The following is a description of a gene set: studied in species Homo sapiens After being synthesized in the ER membrane the 14-sugars lipid-linked oligosaccharide is co-translationally transferred to an unfolded protein, as described in the previous steps. After this point the N-glycan is progressively trimmed of the three glucoses and some of the mannoses before the protein is transported to the cis-Golgi. The role of these trimming reactions is that the N-glycan attached to an unfolded glycoprotein in the ER assume the role of 'tags' that direct the interactions of the glycoprotein with different elements that mediate its folding. The removal of the two outer glucoses leads to an N-glycan with only one glucose, which is a signal for the binding of either one of two chaperone proteins, calnexin (CNX) and calreticulin (CRT). These chaperones provide an environment where the protein can fold more easily. The interaction with these proteins is not transient and is terminated by the trimming of the last remaining glucose, after which the glycoprotein is released from CNX or CRT and directed to the ER Quality Control compartment (ERQC) if it still has folding defects, or transported to the Golgi if the folding is correct. The involvement of N-glycans in the folding quality control of proteins in the ER explains why this form of glycosylation is so important, and why defects in the enzymes involved in these reactions are frequently associated with congenital diseases. However, there are many unknown points in this process, as it is known that even proteins without N-glycosylation sites can be folded properly (Caramelo JJ and Parodi AJ, 2008). Reactome Pathway: N-glycan trimming in the ER and Calnexin/Calreticulin cycle part of: Asparagine N-linked glycosylation, and this is the list of marker genes: OS9, PDIA3, ENGASE, RNF139, SYVN1, DERL1, RNF185, GANAB, EDEM2, UBXN1, AMFR, PSMC1, SEL1L, CALR, VCP, DERL2, UBC, RAD23B, CANX, RNF5, UGGT2, UBA52, MOGS, MLEC, EDEM3, EDEM1, RPS27A, UBB, RNF103, PRKCSH, MAN1B1, MARCHF6, NGLY1, TRIM13, UGGT1